Given this list of marker genes Smarcb1, Ercc6, Sirt7, Ubtfl1 (NCBI Gene Id 546118), Mtor, Wdr75, Atf4, Ncl, Ddx21, Ppp1r15a (protein phosphatase 1, regulatory subunit 15A), Ippk, Nop53, Nol11, Macroh2a2, Ddx11, Ubtf, Smarca5, Pwp1, Crebbp, Mybbp1a, Phf8, Dek, Baz2a, Eif2ak3, Lyar, Bnc1, Wdr43 (NCBI Gene Id 72515), Flna, Sf3b1, Mars1, Actr6, Smarca4, Erbb2, Macroh2a1, Prr7 (NCBI Gene Id 432763), Baz1b, Pih1d1, Maf1, Pdcd7, Zmpste24, Dhx33, Dedd, Heatr1, Utp15, Myo1c, Rasl11a, here is a description of the gene set: Any process that modulates the frequency, rate or extent of transcription mediated by RNA polymerase I. Mouse Gene Set: GOBP_REGULATION_OF_TRANSCRIPTION_BY_RNA_POLYMERASE_I studied in species Mus musculus